The following is a description of a gene set: species: Homo sapiens Bone remodeling. Human Gene Set: MODULE_234, and this is the list of marker genes: DLX5, BMP5, CLEC3A, FGFR3, FRZB, SPP2, IGF1, TNFRSF11B, BMP1, TCF15, PRELP, COL1A1, COL12A1, COL10A1 (NCBI Gene Id 93042), BMP2, SNAI1, PTH1R, IGF2, GHR, ALX1, NPR3, ZBTB16, FGFR1, IL6, SOX9, FBN1, CLEC3B, AEBP1, CALCA, IL6R, CNMD, MGP, JAK3, ETS2 (ETS proto-oncogene 2, transcription factor), TWIST1, MSX1, EXTL1, JAK2, HOXD13, BMP7, NKX3-2, LUM, INHBA, SPARC, IBSP, POSTN, LECT2, BMP4, DLX3, COMP, COL9A2, COL11A1, SPOCK2, TIE1